The following is a description of a gene set: Human Gene Set: HP_HIGH_NARROW_PALATE The presence of a high and narrow palate. High, narrow palate species: Homo sapiens, and this is the list of marker genes: TGFB3, PIGA, SMAD3, MAT2A, DVL3, IPO8, CDT1, RECQL4, ACTA2, ORC4, MYLK, PIEZO2, SMS, GMNN, ORC1, TARS1, TBCK, AMER1, PIGT, KDM6A, HEY2, SKI, COL11A1, MED12L, PLOD1, MPLKIP, GRB10, NONO, FOXE3, HNRNPK, CPT2, NAA10, SMARCA2, GTF2H5, RUNX2, SPRED2, AARS1, COPB1, COL3A1, FZD2, MYH11, DDX59, TGFBR1, CHD6, CDC6, DVL1, AFF4, MARS1, TGFBR2, CRKL, BCOR, LOX, GPC3, THSD4, ORC6, IFT122, GIPC1, SLC25A24, MAPK1, GNE, ASXL3, WASHC5, CCDC22, MCM3AP, NSD1, VPS13B, MFAP5, TAF1, CARS1, UFC1, SLC6A17, DPYSL5, SMAD4 (SMAD family member 4), MAP3K7, EP300, TAOK1, ACTA1, TBX1, BCR, MUSK, DIS3L2, MEGF8, CDK10, TPM3, BBS1, DPM1, RNF113A, ELN, PEX1, SMG9, ARL6 (ADP ribosylation factor like GTPase 6), ERMARD, FGFR3, H4C5, FBN1, PCLO, RET, NEB, PEX5, BMPR1A, ERCC3, ANTXR1 (NCBI Gene Id 84168), MED25, SPTBN1 (spectrin beta, non-erythrocytic 1), ERCC2, PTPN11, ARID2, KIF26A, PCDHGC4, ATP7A, APC, WNT5A, NDUFAF6, FIG4, SIN3A, KMT2D, LRP4, UBE3B, CDC45, KCNK9, FOXP2, POR (cytochrome p450 oxidoreductase), SCARF2, FGFR1, PRKG1, SLC25A12, TGFB2, PTDSS1, RILPL1, BRAF, HECW2, CREBBP, VAC14, SPRED1, SPEN, KLHL41, ABCC6, NOTCH3, MAP2K1, GPC4, ADNP, ATN1, SMAD2, TCTN3, MYMX, CCDC28B, PTEN, VPS35L, COL12A1, GTF2E2, LRP12, NOTCH2NLC, WNT7A, INTU, CNTN1